Given this list of marker genes TSPO, VWA1, NTRK1, SCN9A (sodium voltage-gated channel alpha subunit 9), CAPN2, ADAM11, MTOR, AKT1, TRPV1, THBS1, LPAR5, SCN3A, P2RX2, P2RX3, P2RX4, THBS4, GRIA1, SCN11A, TACR1, PIRT, here is a description of the gene set: Any process that results in a change in the behavior of an organism as a result of a pain stimulus. Pain stimuli cause activation of nociceptors, peripheral receptors for pain, include receptors which are sensitive to painful mechanical stimuli, extreme heat or cold, and chemical stimuli. Human Gene Set: GOBP_BEHAVIORAL_RESPONSE_TO_PAIN species: Homo sapiens